Given this list of marker genes Rtraf, Rtcb, Fam98a, Zbtb8os, Fam98b, Ddx1, AI597479, Fam98c, here is a description of the gene set: Mouse Gene Set: GOCC_TRNA_SPLICING_LIGASE_COMPLEX A protein complex that catalyzes the ligation of cleaved pre-tRNAs by directly joining spliced tRNA halves to mature-sized tRNAs by incorporating the precursor-derived splice junction phosphate into the mature tRNA as a canonical 3',5'-phosphodiester. species: Mus musculus